The following is a description of a gene set: Abnormality of the costochondral junction Human Gene Set: HP_ABNORMALITY_OF_THE_COSTOCHONDRAL_JUNCTION studied in species Homo sapiens Any anomaly of the costochondral junction. The costochondral junctions are located between the distal part of the ribs and the costal cartilages, which are bars of hyaline cartilage that connect the ribs to the sternum., and this is the list of marker genes: ARSL, SRP54, DYM (dymeclin), PRKG2, RTL1, SBDS, DDR2, MEG3, FGFR3, SLC34A3, CYP27B1 (cytochrome P450 family 27 subfamily B member 1), CYP2R1 (NCBI Gene Id 79445), VDR, SLC26A1, PHEX, NOG, DNAJC21, SLC34A1, CTNS, DLK1, ALPL